Given this list of marker genes FAM216A, BACE1, SNRNP25, NUDT3, SLC9A9, PDK3, GPR160, ESYT1, ZG16B, BIN2, ASB13, DIS3L, ESCO2, TATDN2, LINC00921, SULT1A1, MTARC1, HLA-DRB6, REX1BD, IDH3G, P2RY13, MTX1, MPPE1, C6orf58, NREP, MCM5, ZBTB43, CHN2, SH3BGRL, NXT1, POGLUT3, SNTB1, CELF6, MZT2A, F5, ALDH3B1, STX11, CDK5RAP1 (CDK5 regulatory subunit associated protein 1), GARS1-DT, TMEM14C, BABAM1, TOR2A, DNMT3A, AMT, TXNDC11, GPD1L, SLC18B1, LSM14A, ARHGAP15, NAPB, TMX4, NR4A3, GPBAR1, ELMO1, DAP, CINP, YDJC, NR4A1, PPT1, MGST2, UROS, RASGRP2, DENND1C (DENN domain containing 1C), AKAP8, ALAD, DDAH2, ZFP36, POLB, ZCCHC24, TRIM8, SPAM1, VAV2, LIMD2 (LIM domain containing 2), CIDEB, CD37, TMEM183A, CLEC11A, GSE1 (NCBI Gene Id 23199), NAPRT, S1PR3, TMEM39B, RNASE2, WAS, PIH1D1, PSMB9, TTTY14, CHRAC1, ITGA4, MMP25, ETFB, ZNF652, TSHZ1, HNRNPA3P1, ACBD6, RPS6KA4, ATP5IF1, ZBED10P, LRMDA, ASGR1, FAF1, SNHG15, PRKX, SND1, PTP4A1, SLC39A11, EPB41, NDUFS7, PRC1, PEBP1, MBTPS1, THUMPD2, VAMP5, BAZ2A, AMZ2, PSTPIP1, PYGL, CCDC88C, ELAC2, SARAF, PRKAR2B, ABHD14B, DHPS, CDK6, USP3, ATP5ME, TKT, GMDS, TM7SF3, C11orf21, TTC3 (NCBI Gene Id 7267), LTA4H, GSDMD, RERE, TLE3, RPH3A, CAPNS1, COQ8A, ACSF2, MTMR1, FBXL17, CCDC6, EXOSC5, ERICH1, ENDOD1, SIN3B (NCBI Gene Id 23309), MUSTN1, EZR, THYN1, KBTBD11, MIB2, MIF4GD, DCTN3, MAN1B1, NAPSB, ASGR2, OGFOD3, TACC3, MAP4K1, OCEL1, CRISPLD2, KLF11, ANAPC15, TMC8, ELF1, FAM228B, REM2, EIF2D, CRYL1, MSRB2, APBB3, ARMH1, KLF7, CDK5, SLC48A1, NDUFS4, SELENOP, ORMDL1 (ORMDL sphingolipid biosynthesis regulator 1), MPP7, MPC1, ZNF185, EPRS1, AKT1, KLF2, TTYH2, MAPRE2, HSH2D, ELANE, SLC39A4, CAMK2G, TAFAZZIN, PCIF1, IGFBP7, MIDEAS, NDRG3, WBP11, TMT1A, here is a description of the gene set: from publication Lund R, Aittokallio T, Nevalainen O, Lahesmaa R (PMID 14607935) Human Gene Set: GSE2770_IL12_AND_TGFB_ACT_VS_ACT_CD4_TCELL_2H_DN Th1 and Th2 cells arise from a common precursor cell in response to triggering through the TCR and cytokine receptors for IL-12 or IL-4. This leads to activation of complex signaling pathways, which are not known in detail. Disturbances in the balance between type 1 and type 2 responses can lead to certain immune-mediated diseases. Thus, it is important to understand how Th1 and Th2 cells are generated. To clarify the mechanisms as to how IL-12 and IL-4 induce Th1 and Th2 differentiation and how TGF-beta can inhibit this process, we have used oligonucleotide arrays to examine the early polarization of Th1 and Th2 cells in the presence and absence of TGF-beta after 0, 2, 6 and 48 hours of polarization. studied in species Homo sapiens Genes down-regulated in CD4 T cells activated by anti-CD3 and anti-CD28: TGFB1 and IL-12 (2h) versus untreated (2h).